The following is a description of a gene set: The presence of one or more obsessive-compulsive personality traits. Obsessions refer to persistent intrusive thoughts, and compulsions to intrusive behaviors, which the affected person experiences as involuntary, senseless, or repugnant. Human Gene Set: HP_OBSESSIVE_COMPULSIVE_TRAIT species: Homo sapiens Obsessive-compulsive trait, and this is the list of marker genes: PCDH19, GATAD2B, FGF13, DMPK, GABRG2, ASCC3, YWHAG, FMO3, SCN2A, ASH1L, SCN9A, SNRPN, CBS, MAGEL2, FMR1 (NCBI Gene Id 5421), ADGRV1, ELN, SLC45A1, STX1B, GABRA1, PRRT2, SYNGAP1, HCN1, USP7, PANK2, TRIO, MLXIPL, SCN1A, NDN, GABRD, TIAM1, SCN1B, OCA2